The following is a description of a gene set: BMP receptor signaling Human Gene Set: PID_BMP_PATHWAY from publication Schaefer CF, Anthony K, Krupa S, Buchoff J, Day M, Hannay T, Buetow KH (PMID 18832364) studied in species Homo sapiens, and this is the list of marker genes: SMAD6, BAMBI, CER1, TAB1, BMPR2 (bone morphogenetic protein receptor type 2), BMPR1A, ZFYVE16, GSK3B, SMURF2, RGMB, CHRDL1, SKI, FST, SMAD5, PPP1CA, PPM1A, GREM1, SMAD7, MAP3K7, NOG, SMAD4, AHSG, BMPR1B, CHRD, XIAP, MAPK1, SOSTDC1, SMURF1, CTDSP1, CTDSP2, RGMA, BMP6, BMP2, HJV, CTDSPL, TAB2, PPP1R15A, SMAD9, BMP4, SMAD1, NUP214, BMP7